Given this list of marker genes Tfe3, Neurod1, Hdac1, Prmt5, Neurog3, Ascl1, Bhlhe41, Olig1, Bhlhe23, Bmal2, Srebf2, Figla, Nr1d1, Myc, Snai1, Atoh1, Zeb1, Cry1, Neurog2, Myog, Max, Bmyc, Hand2, Tfap4, Neurog1, Gata3, Tal1, Tcf21, Bhlhe40, Myod1, Hes1, Ascl2, Neurod6 (NCBI Gene Id 11922), Atoh8, Snai2, Tcf15, Bmal1, Twist1, Ptf1a, Scx, Bhlhe22, Mybbp1a, Neurod2, Mitf, Ahr, Ciart, Hif1a, Clock, Spz1, Olig3, Bhlha15, Pparg, Atoh7, Tcf3, Neurod4, Tcf12, Olig2, Tcf4, Per1, here is a description of the gene set: Mouse Gene Set: GOMF_E_BOX_BINDING species: Mus musculus Binding to an E-box, a DNA motif with the consensus sequence CANNTG that is found in the promoters of a wide array of genes expressed in neurons, muscle and other tissues.